The following is a description of a gene set: Human Gene Set: MIR6777_3P studied in species Homo sapiens from publication Chen Y, Wang X (PMID 31504780) Genes predicted to be targets of miRBase v22 microRNA hsa-miR-6777-3p in miRDB v6.0 with MirTarget v4 prediction scores > 80 (high confidence targets)., and this is the list of marker genes: PIWIL4 (piwi like RNA-mediated gene silencing 4), ULK2, PRAMEF15 (NCBI Gene Id 653619), SH3BGRL2, NDUFC2-KCTD14, CNKSR2, SNX24, CLPX, GNAS, PRSS21, PCBP1, PRAMEF4, ZFP64, ARHGEF35, VCAN, EIF4E3, SLC6A2, NCSTN, KCTD14, LRATD1, NR4A3, LRIT3, MAPKBP1, RNF138 (ring finger protein 138), PPP1R3F, PRAMEF5, HRH1, PRRC2B, RMND5A, SPATA4, FAT3 (NCBI Gene Id 440062), ZNF385B, RNPS1, UCK2, HSPA5, FST, CDX1, PCBP2, PRAMEF25, TAF5L, PTPRG, IRX1, KLK15, ZNF687, RRM2B, NOP16, RXRB, AASDH, CETN3, SEPTIN8, QKI, EIF2S2, PCTP, IFNE, CLVS2